The following is a description of a gene set: Hypocalcemic vitamin D analogs are appealing molecules to exploit the immunomodulatory actions of active vitamin D in vivo. The functional modulation of dendritic cells is regarded as the key mechanism underlying their ability to regulate T cell responses. In contrast, the direct actions of vitamin D and structural analogs on T lymphocytes remain less well characterized. Microarray analysis was performed to gain insight into the direct immunomodulatory actions of TX527, a hypocalcemic vitamin D analog, on human T lymphocytes. Gene expression analysis revealed that TX527 regulated a wide variety of genes involved in different aspects of T cell function, including cellular growth and proliferation, cell death, cellular development, cellular movement and cell-to-cell signalling and interaction. Genes up-regulated in T cells: control versus TX527 (hypocalemic analog of 25-hydroxyvitamin D3). from publication Baeke F, Korf H, Overbergh L, Verstuyf A, Thorrez L, Van Lommel L, Waer M, Schuit F, Gysemans C, Mathieu C (PMID 21131424) Human Gene Set: GSE23984_CTRL_VS_HYPOCALEMIC_VITAMIND_ANALOG_TCELL_UP studied in species Homo sapiens, and this is the list of marker genes: JDP2, UFSP2, SLITRK3, MYD88, FOXL2, MED14, EMC2 (NCBI Gene Id 9694), RFX5, CHCT1, C19orf38, EFNA2, SLC25A12, TREM1, PROCR, PARK7, CD33, TMEM170B, NLRX1, VMP1, PSEN1, IDI1, CS, TCP10L, GBE1, SLC13A3 (solute carrier family 13 member 3), SUN1, IL13RA1, BTG1, PTGES2, NUDT19, COQ8A, DMPK, NCBP3, TANK, ZDHHC5 (NCBI Gene Id 25921), PIK3R5, GLYCTK, SESN2, CD38, PDZD11, CHSY1, PECAM1, MAP2, TRAF3, CSE1L, AP2S1 (NCBI Gene Id 9161), PAFAH1B2, COX6A1, CEACAM21, LANCL3, SH2B2, CCT2, ARHGEF37, PPP1R21, METAP1, SLC25A1, AP3M1, CYB5B, LPCAT3, SDHD, SPINT2, DNER, PTGES, IMPDH2, RGCC, CAPNS1, CPD, NUS1, BLCAP, EVA1B, DMXL2, TRPS1 (transcriptional repressor GATA binding 1), RAB10, MRPS11, TXN, FKBP15, OGDH, PRXL2B, DDT, TPMT, PSTPIP1, AP1G2, KLF7, NECTIN2, SPIDR, PTGIR, CBX5, CCDC125, CNIH4 (NCBI Gene Id 29097), GLB1, TRAPPC2, NTAQ1, DCAF1, SNF8, AGPAT5, TM7SF2, NPL, CLMP, STARD7 (StAR related lipid transfer domain containing 7), MEGF9, PKM, MDH2, TYMS, PRELID3B, PARP3, CP, AIFM2, NDUFS6, SLC4A7, SMAD6, RASIP1, ARL5A (NCBI Gene Id 26225), CRTC3, ETHE1, FGR, HYAL2, TMEM123, HSD17B7, CNPY4, PCDH7, RC3H1, XPNPEP1, DDIT4 (NCBI Gene Id 54541), MSR1, ATP6V0C, CTSC, PHETA1, GPD2, UBAC2, LANCL2, PARL, PPBP, JAK2, FASN, SYN1, ENO3, ALDH3B1, PMVK, VHL, GNG12, PSMA7, PRELID2, AARS1, ATP5F1D, GAB1, VEGFA, HNRNPA1, ZNHIT1, LCMT1, ADGRL2, EGR2, UQCR10, MTHFD2, AACS, C19orf25, LCN2, ATP6V1E1, UBXN8, AIMP2 (aminoacyl tRNA synthetase complex interacting multifunctional protein 2), APP, ADRA2C, MGAT4A, SLC37A4, VPS29, ZBTB18, ABRACL, TIMM10B, MIF, ATP5MC1, SLC6A13, AFP, GPR132, FADS2, CLYBL, C1QBP, SLC25A10, PSMD10, PGP, BAZ1A, SCAMP1, RPS6KA4, CRELD1, EMILIN2, ABHD11, ODC1, MAPRE1, STX12, SRA1, RIOX2, CYP51A1, C1R, TUBA4A, MRPL45, IGF2R, SIGLEC7, PDPN, IPO13, TUBB, STING1, MCEMP1